The following is a description of a gene set: Nemaline rods are abnormal bodies that can occur in skeletal muscle fibers. The rods can be observed on histological analysis of muscle biopsy tissue or upon electron microscopy, where they appear either as extensions of sarcomeric Z-lines, in random array without obvious attachment to Z-lines (often in areas devoid of sarcomeres) or in large clusters localized at the sarcolemma or intermyofibrillar spaces. Human Gene Set: HP_NEMALINE_BODIES Nemaline bodies studied in species Homo sapiens, and this is the list of marker genes: CFL2, KLHL41, TPM2, LMOD3, COX11, ADSS1, TNNT1, KBTBD13, MYO18B, RYR3, NDUFB3, NEFL, TPM3, RYR1, ACTA1, MYPN, NEB, PYROXD1, KY (NCBI Gene Id 339855), KLHL40